The following is a description of a gene set: Creatine metabolism Human Gene Set: REACTOME_CREATINE_METABOLISM studied in species Homo sapiens, and this is the list of marker genes: GATM (glycine amidinotransferase), SLC6A8, CKMT1B, SLC6A11, CKB, CKMT1A, GAMT, CKM, SLC6A12, SLC6A7, CKMT2 (NCBI Gene Id 1160)